The following is a description of a gene set: studied in species Mus musculus Mouse Gene Set: GOCC_ENDOPLASMIC_RETICULUM_PLASMA_MEMBRANE_CONTACT_SITE A contact site between the endoplasmic reticulum membrane and the plasma membrane, structured by bridging complexes., and this is the list of marker genes: Gramd1b, C2cd2l, Stimate, Esyt3 (extended synaptotagmin-like protein 3), Saraf, Osbpl5, Sacm1l, Bltp2, Bltp1, Gramd1a, Esyt2, Gramd1c